Given this list of marker genes RRBP1, ACOT2, YBX1, DAD1, P4HA1, FASN, DENCMEMSB, DNAJC3, IPO7, P4HA3, BTF3, HSPA8, SCAP, BAG2 (BAG cochaperone 2), EIF4A1, UBA52, UFD1, KPNA1, DDOST (NCBI Gene Id 1650), HSPA1A, RPS27A, OST4, VCP, UBC, STT3B (STT3 oligosaccharyltransferase complex catalytic subunit B), KPNA2, UBE2I, PABPC1, HSPA1B, RPN1, DNAJB11, DPM1, HSPA5, CALR, KPNB1, SUMO1 (small ubiquitin like modifier 1), P4HB, EIF4E, HYOU1, SEC11C, KPNA7, PRKG2, EIF4G3, TMEM258, RTN3, TUSC3, NPLOC4, DPM3 (dolichyl-phosphate mannosyltransferase subunit 3, regulatory), DPM2, RPN2 (ribophorin II), EIF4G1, EIF4E3, UBB, MAGT1, SPCS2, MAP1LC3B, KPNA3, SEC11A, EIF4A3, SUN2, NMT1, EIF4A2, HDLBP, NACA, STT3A, EIF4G2, PDIA3, ATL2 (atlastin GTPase 2), HNRNPD, KPNA4, VIM, KPNA5, DNAJA2, DNAJC10, XPO1, OSTC, SPCS1, SPCS3, APOA1, CANX, XRN1, P4HA2, PRKG1, here is a description of the gene set: part of: Dengue Virus Infection studied in species Homo sapiens Reactome Pathway: Dengue Virus Genome Translation and Replication The DENV Replication Complex (RC) contains all seven DENV nonstructural proteins, which catalyze the membrane-bending and genome replication processes. Its core consists of the NS3 and NS5 proteins that enable all replication steps from preparing the RNA template, to polymerization and capping. The other proteins create a suitable environment by bending the ER membrane to a nearly closed loop, which protects the RC while still allowing access to cytosolic resources.<br><br>The genetic material of the Dengue virus (DENV) is a positive sense single-strand RNA molecule (+ssRNA) that, upon release into the host cell cytosol, can directly be translated by host cell ribosomes. The translation of the DENV genomic RNA produces a single polyprotein that is co- and post-translationally cleaved by both viral and host proteases into three structural proteins (C, prM, E) and seven nonstructural proteins (NS1, NS2A, NS2B, NS3, NS4A, NS4B, NS5). The polyprotein's signal- and stop-transfer sequences direct its back-and-forth translocation across the endoplasmic reticulum (ER) membrane.<br><br>The DENV replication complex assembles at and is anchored to the endoplasmic reticulum (ER) membrane, where it forms specialized structures called replication vesicles or replication organelles.<br><br>The replication of the DENV genomic RNA involves the synthesis of the negative sense RNA (-ssRNA) intermediate, in which the DENV replication complex uses the genomic +ssRNA as a template to synthesize a complementary -ssRNA molecule. Subsequently, this -ssRNA serves as a template for the production of new +ssRNA genomes. Newly synthesized genomic +ssRNA molecules can be used for further translation, to produce more viral proteins, or can be packaged into new virions.<br><br>The DENV genomic +ssRNA is 5′-capped with a unique 5′-stem-loop structure (SLA for stem-loop A), which is essential for RNA replication and 5′ capping. The fate of viral RNA during translation, replication and assembly is reviewed in Hodge et al., 2019 and Abram et al., 2024.